Given this list of marker genes SRI, RRAD, GSTM2, PHPT1, CABP2, ATP2A3, GRM3, REM1, CALM3, SGK1, STIM1, SGK3, CRISP1, NRXN2, MICU3, PRKG1, CACNG4, TSPAN13, PDE4B, NRXN1, CABP4, REM2, TNNI3, CALM1, CACNB3, CACNG7, CAV3, C8orf44-SGK3, YWHAE, CABP5, SLC30A1, STIMATE, ITPR1, CACNG1, GEM, CALM2, AMBP, GRM2, STIM2, FKBP1A, CACNB1, RASA3, CACNG8, STX1A, CABP1, PACSIN3, ATP2A2, NPY, MICU2, PRKCB, MCUB, NOS1, CACNG6, PDE4D, FKBP1B, HPCAL4, NPY2R, MICU1, here is a description of the gene set: Modulates the activity of a calcium channel. species: Homo sapiens Human Gene Set: GOMF_CALCIUM_CHANNEL_REGULATOR_ACTIVITY